The following is a description of a gene set: Human Gene Set: MODULE_186 Genes in the cancer module 186. species: Homo sapiens, and this is the list of marker genes: LTBP2, ABCG1, SLC10A2, SLC7A9, SLC7A5, SLC16A8, SLC16A3, SLC16A4, SLC16A1, SLC26A3, SLC3A1, SLC38A3, SLCO1A2, SLC10A1, SLC7A2, SLC1A3, SLC16A2, AKR1C4, ABCC3, SLC1A6